Given this list of marker genes Nppc, Wee2, Npr2, Shb, Grb14, here is a description of the gene set: species: Mus musculus Any process that stops, prevents or reduces the frequency, rate or extent of oocyte maturation. Mouse Gene Set: GOBP_NEGATIVE_REGULATION_OF_OOCYTE_MATURATION